Given this list of marker genes Cyp1b1, Cyp7a1, Cyp2c39, Cyp2j5, Cyp2b23, Cyp51, Cyp3a41b, Cyp2c38, Cyp39a1, Akr1c6, Dohh, Cyp2d22, Cyp27a1, Akr1c20, Hsp90ab1, Cyp26c1, Cyp2j6, Cyp2b19, Akr1c14, Cyp3a25, Cyp2a22, Cyp2g1, Cyp2c66, Nos1, Cyp3a16, Ahr, Cyp2d34, Tph1, Hmox2, Fmo3, Gm4847, Cyp2r1, Cyp2c50, Cyp26b1, Cyp4a10, Cyp4f15, Atp2b4, Nos2, Cyp2c54, Cyp2d12 (NCBI Gene Id 380997), Gm4846, Mical3, Cyp4a32, Cyp4a31, Ndufs7, Cyp1a1, Cyp2c23, Cyp2e1, Cyp3a41a, Faxdc2, Foxred2, Akr1c13, Cyp11a1 (cytochrome P450, family 11, subfamily a, polypeptide 1), Cyp2b13, Cyp3a11, Cyp2j9, Cyp3a44, Cyp8b1, Cyp2d10, Cyp2u1, Cyp2c67, Cmah, Cyp2f2, Calm1, Agmo, Cyp2j13, Miox, Cyp7b1, Cyp2c29, Cyp2j7, Cyp11b2, Fdx1, Cyp2a12, Calm3, Coq6, Pam, Ndufaf5, Tyr, Cyp4f39, Cyp2d26, Coq7, Cyp21a1, Cyp2d9 (NCBI Gene Id 13105), Jmjd7, Ch25h, Cyp2c68, Akr1c19, Cyp2c40, Cyp17a1, Akt1, Cyp2w1, Fmo6, Cyp4f40, Fmo1, Moxd2, Cyp2c55 (NCBI Gene Id 72082), Cyp3a59, Cyp3a57, Cyp3a13, Cyp4a14, Fmo2, Cyp4x1, Cyp2d40, Cyp4f14, Akr1c18, Cyp2j11, Cyp2j12, Cyp19a1, Cyp1a2, Cyp20a1 (NCBI Gene Id 77951), Cyp24a1, Cyp2b10, Moxd1, Akr1c21, Pcbd2, Cyp27b1 (cytochrome P450, family 27, subfamily b, polypeptide 1), Tbxas1, Fmo4, Akr1c12 (NCBI Gene Id 630950), Cyp4a30b, Cyp4f18, Cyp2b9, Degs2, Cyp2j8, Cyp2c65, Mical2, Th, Cyp2s1, Cyp4v3, Sqle, Cyp26a1, Cyp2c37, Cyp4a12a, Cyp11b1, Fmo9, Cyp4f13, Cyp2ab1, Cyp4a12b, Cyp2d11, Mical1, Cyp2c70, Nos3, Cyp4a29, Park7, Ptgis, Cyp4b1, Dynll1, Cyp2t4, Cyp46a1, Pcbd1, Cyp2c69, Kmo, Tph2 (NCBI Gene Id 237554), Cyp2a5, Hmox1, Msmo1, Tyrp1, Hsp90aa1, Calm2, Akr1d1, Dbh, Akr1cl, Pah, Fa2h, Cyp2a4, Fmo5, here is a description of the gene set: Catalysis of the incorporation of one atom from molecular oxygen into a compound and the reduction of the other atom of oxygen to water. Mouse Gene Set: GOMF_MONOOXYGENASE_ACTIVITY studied in species Mus musculus